The following is a description of a gene set: species: Homo sapiens Human Gene Set: HP_AUTOIMMUNE_HEMOLYTIC_ANEMIA An autoimmune form of hemolytic anemia. Autoimmune hemolytic anemia, and this is the list of marker genes: RFX5, LRBA, RFXAP, ARPC5, CIITA, NFKB1, ACP5, DEF6, ZAP70, STAT1, PI4KA, STK4, IL2RB, IL2RA, PRKCD, STAT3, PIK3CG, ADA (adenosine deaminase), TTC7A, RAG2, PSMG2, FASLG, DOCK11, FAS, PNP, STIM1, CTLA4, ITK, CASP10, TRAC, NLRP1, RAG1, RFXANK, NBN, CD247, WAS, CD3G, TLR8, TPP2, RASGRP1, FOXP3, DRG1, CBLB, LCP2